The following is a description of a gene set: species: Mus musculus Mouse Gene Set: GOBP_PLASMA_MEMBRANE_RAFT_ORGANIZATION A process that is carried out at the cellular level which results in the assembly, arrangement of constituent parts, or disassembly of plasma membrane rafts., and this is the list of marker genes: Cav1, Fa2h, Iqgap1, Col6a1, Flot1, Pacsin2, Cav2, Ilk, Colec12, Abca7, Cln3, Cav3, Emp2